The following is a description of a gene set: Human Gene Set: GSE36888_STAT5_AB_KNOCKIN_VS_WT_TCELL_IL2_TREATED_2H_DN studied in species Homo sapiens Genes down-regulated in T cells stimulated by IL2 for 2h: STAT5 double knock-in versus wildtype. Cytokine-activated STAT proteins dimerize and bind to high-affinity motifs, and N-terminal domain-mediated oligomerization of dimers allows tetramer formation and binding to low-affinity tandem motifs, but the functions of dimers versus tetramers are unknown. We generated Stat5a and Stat5b double knock-in (DKI) N-domain mutant mice that form dimers but not tetramers, identified cytokine-regulated genes whose expression required STAT5 tetramers, and defined consensus motifs for dimers versus tetramers. Whereas Stat5- deficient mice exhibited perinatal lethality, DKI mice were viable, indicating that STAT5 dimers were sufficient for survival. Nevertheless, STAT5 DKI mice had fewer CD4+CD25+ T cells, NK cells, and CD8+ T cells, with impaired cytokine-induced proliferation and homeostatic proliferation of CD8+ T cells. DKI CD8+ T cell proliferation following viral infection was diminished and DKI Treg cells did not efficiently control colitis. Thus, tetramerization of STAT5 is dispensable for survival but is critical for cytokine responses and normal immune function. from publication Lin JX, Li P, Liu D, Jin HT, He J, Ata Ur Rasheed M, Rochman Y, Wang L, Cui K, Liu C, Kelsall BL, Ahmed R, Leonard WJ (PMID 22520852), and this is the list of marker genes: C1orf115, PTAFR, SPTSSA, SCARB1, DDRGK1, DUSP3, ZCCHC24 (zinc finger CCHC-type containing 24), JPH4, ACTN1, VNN2, PRRG4, ZNF358, MRFAP1, CES1, AHR, PLCB1 (NCBI Gene Id 23236), LTB4R, LAMB2, MRPL33, RNASE4, HOMER3, BNIP3L, EIF4G3, TMEM170B, FNDC3B (fibronectin type III domain containing 3B), SLC17A5, PHAF1, PRNP, TNFSF8, PAAF1, CELSR2, ENSG00000254531 (novel transcript), OLA1, PLXDC2, PELO, JAG1, ASGR2, TCEAL1, PLD1, HFE, TMEM270, CARS2, CD1A, IRF2BP2, SIRPA, TRIM3, HNRNPLL, ATXN1, NOD2, C12orf76, CLEC10A, BLMH, TMEM38A, RAB13, FNTB, SCPEP1, MEGF9, ARHGAP24, SEC61B, CC2D2A, ETHE1, BCS1L, UBTD1, HEXA, TSHZ3, MARVELD1, AQP9, PSRC1, CD1D, STEAP4, CMTM3, CYB5R1, GPX1, GCA, BLVRB, MPO, ST14, ZFP64, STARD7, EFHC1, TNFAIP3, CANX, LINC02724, TP53I3, KPTN, NLRP12, HLX, MICAL2, ZNF467, CUTA, NSMAF, SCYL1, A1BG, SGMS2, SFPQ, ARHGEF10L, C15orf48, ZNF277, CATSPER1, CCNYL1, RNF41, FAM200B, MIF4GD, STAM, NME8, ABCC12, SLC16A5, ANG, F11R, CLIC4, SPG21, VAPA, DYNC2H1, NQO1, CTSH, PLA2G7, OTULINL, ZNF775, HMGB2, LYZ, PARP8, CRISPLD2, SMARCD3, EIF2S3, ATP6V1A, APBA3, LATS2, PTRHD1, SYNGR1, TRIOBP, MYCL, C16orf74, CNPY2, CYP2S1, ACAP1, SLC2A3, RUNX2, MPP7, LPGAT1, IL6R, TEX2, SUSD3, HBEGF, EXT2, SEMA3C, ADAM9, EGR2, STK32B, IL13RA1, ZC3H11A, ALOX5AP, CFAP418, ITGAM (NCBI Gene Id 3684), IL17RA, FAR2, CDKL1, ANO10, SLC48A1, NAIP, PTPRN2, F5, ZNF804A, CTDSPL, VEGFA, TOP3A, BATF (basic leucine zipper ATF-like transcription factor), STX3, CLMN, F13A1, AGTRAP, TRIM59, IL1B, SLC43A1, SELL, SNTB1, CLEC5A, TREM1, ASB13, FBN2, KLHL23, ATPAF2, AFAP1, UIMC1, CCNY, APCDD1L, LINC00205, EFCAB2, NRGN, LIN7A, COLEC12 (NCBI Gene Id 81035), UXS1, LAMTOR1, ALDH2, ZNF428, ANO5, FMO5, EMB